The following is a description of a gene set: studied in species Homo sapiens Human Gene Set: MODULE_111 Genes in the cancer module 111., and this is the list of marker genes: HSF4, SLC18A1, DHRS2 (dehydrogenase/reductase 2), CD5, MVK, HAAO, NHERF2, TACR3, TAF1, CD8B, MPZ, KRT2, CDH5, NNAT, SPTB, IL1RN (NCBI Gene Id 3557), SPRR2C, CNTN1, CD33, MEF2C, ATF6B, RAPGEF5, NGFR, CLCNKA, ZNF132, GCK, PAX6 (paired box 6), PTPRU, ZNF143, CFAP410, AIF1, CEACAM4, FHL3, FUT7 (fucosyltransferase 7), TUB (NCBI Gene Id 7275), MYO1E, MME, ITIH4, GOLGA1, STAT4, PBX1, WAS, GNG4, ATP6V1B1, BGN, OAS2, HNF4A, ZKSCAN7, CSNK2A2 (casein kinase 2 alpha 2), GRM4, PAX8, PLGLB2, CALB2, AFAP1, KRT6A, POLA2, MYBPC1, SLC6A9 (solute carrier family 6 member 9), ADCYAP1, FGR, EZH1, SEMA3F, ARHGAP4, ACVR1B, AVPR1B, FEV, KRT33B, NELL2, SLC30A3, CD22, HLA-DOB, NUDT1, PTGER3 (NCBI Gene Id 5733), RASL10A, KRT31, SLC10A1, ZP2, LGALS9, KRT12, STXBP1, MPP2, DAPK1 (death associated protein kinase 1), VAV2, EDEM1, CYP2A6, PGC, SMPDL3B, FCGR2B, MLANA, BDH1, CXCL5 (C-X-C motif chemokine ligand 5), IGHMBP2, CFB, ZNF592, FLT4, KIR2DL3, PTPRN, FCGR2A, IL2RG, INPP5D, NCKAP1L, TAF15, ELL, FLT1, KCNJ4, CYP2C9, APBA1, PXN, LIF, EFNB1, CXCL9, PSD, CCL2, PHKG1 (NCBI Gene Id 5260), CYP2F1, RGS16, MPP3, SCN1B, P2RX5, MYBPC2 (NCBI Gene Id 9115), CD34, NR1D1, FUT3, PROC, IL4R, MTFR1, CHI3L2, GATA2, PDE4A, ZNF157, CACNB1 (NCBI Gene Id 782), TBXA2R, IKBKE, KRT86, WNT10B, MR1, AQP7, CSRP3, TBR1, E2F1, S100P, GMPR, TNR, CRYAA, DLG4, IRF5, SLC5A2, CHRNE (NCBI Gene Id 83405), CELSR2, EFNA3, GBF1, BNIP1, CTF1